The following is a description of a gene set: SLC25A46 Pathway species: Homo sapiens Human Gene Set: WP_SLC25A46_PATHWAY, and this is the list of marker genes: MICOS10, IMMT, EMC1, EMC8, EMC2, CHCHD6, EMC6, EMC7, SLC25A46, DNM1L, EMC10, MMGT1, APOOL, EMC4, MICOS13, EMC3, MFN1, CHCHD3, OPA1, APOO, MFN2